The following is a description of a gene set: Reactome Pathway: Viral mRNA Translation part of: Influenza Viral RNA Transcription and Replication Spliced and unspliced viral mRNA in the cytoplasm are translated by host cell ribosomal translation machinery. At least ten viral proteins are synthesized: HA, NA, PB1, PB2, PA, NP, NS1, NEP/NS2, M1, and M2. Viral mRNA translation is believed to be enhanced by conserved 5'UTR sequences that interact with the ribosomal machinery and at least one cellular RNA-binding protein, G-rich sequence factor 1 (GRSF-1), has been found to specifically interact with the viral 5' UTRs.. The viral NS1 protein and the cellular protein P58(IPK) enhance viral translation indirectly by preventing the activation of the translational inhibitor PKR. The viral NS1 protein has also been proposed to specifically enhance translation through interaction with host poly(A)-binding protein 1 (PABP1). Simultaneously, host cell protein synthesis is downregulated in influenza virus infection through still uncharacterized mechanisms. In most human influenza A strains (such as PR8), the PB1 mRNA segment is capable of producing a second protein, PB1-F2, from a short +1 open reading frame initiating downstream of the PB1 ORF initiation codon. studied in species Homo sapiens, and this is the list of marker genes: RPS2, RPL30, RPSA, GRSF1, RPS23, RPL3, RPL22L1, RPL34, RPL27, RPL32, RPL36A, RPL24, RPL15, RPLP1, RPL7A, RPL18, 28S rRNA, RPS25, RPLP0, RPL10, RPL11, RPS4X, RPL38, RPS5, RPS3, RPS18, RPS28, RPL36AL, RPS9, RPS27, PB1, RPS13, RPL21, RPL18A, RPL9 (ribosomal protein L9), RPL14, RPL26, RPL23A, RPL31, HA, PA, RPL17, RPS10, RPS6, RPS24, RPS27A, UBA52, RPS14, RPS29, RPL26L1, RPS7, RPS19, RPS8, RPS4Y1, RPS3A, RPL29, RPS17, RPL4, RPS26, 18S rRNA, NS, RPL37, M, RPL8, RPS4Y2, NA, RPL22, RPS27L, RPL35A, RPS15A, 5S rRNA, RPL35, RPL13, RPL36, RPL39, 5.8S rRNA, RPL41, RPL6, RPL10L, RPS20, RPL13A, RPS11, RPL23, PB2, RPL28, DNAJC3, RPS15, RPL5, RPS16 (NCBI Gene Id 6217), RPL3L, RPL37A (ribosomal protein L37a), RPL19, NP, RPL27A, RPLP2, FAU, RPL12, RPS12, RPL7, RPS21, RPL39L, RPL10A